Given this list of marker genes PPP2R1A, LMNA, TUBA1C, RANGAP1 (NCBI Gene Id 6381), VRK1, NUP155, TUBB2A, KPNB1, CHMP6, CHMP2B, TUBA3D, SUMO1, TUBB8, TUBB4A, RAN, TUBB4B, CCNB2, TUBA4A, NUP133, CHMP3 (charged multivesicular body protein 3), TUBA3E, NUP35, TUBA1A, TUBA3C, ANKLE2, TUBB8B, VRK2, TUBB6, SPAST, NUP43, CHMP4A, LMNB1, PPP2CA, TUBB1, BANF1, NUP62 (NCBI Gene Id 51551), TUBA1B, NUP188, NUP205, CDK1, CHMP4C, IST1, POM121 (NCBI Gene Id 9883), RCC1, TUBB3, CHMP7, NUP107, TUBA8, NUP54, NDC1, NUP58, UBE2I, SEH1L (SEH1 like nucleoporin), NUP37, NUP85, AHCTF1, TUBA4B, LEMD3, NUP160, TUBAL3, CHMP2A, PPP2R2A, SEC13, LEMD2, TMPO (thymopoietin), TNPO1, NUP93, CCNB1, CC2D1B, NUP98, LBR, VPS4A, TUBB2B, CHMP4B, EMD, SIRT2, here is a description of the gene set: studied in species Homo sapiens Reassembly of the nuclear envelope (NE) around separated sister chromatids begins in late anaphase and is completed in telophase. Characteristic proteins of the inner nuclear membrane and nuclear lamina accumulate at the reforming NE. Concurrently, nuclear pore complexes (NPCs) assemble and insert into the reforming NE, and the NE becomes sealed to reestablish the nucleocytoplasmic diffusion barrier. part of: Mitotic Anaphase Reactome Pathway: Nuclear Envelope (NE) Reassembly